Given this list of marker genes Esrp1, Rbpj, Notch1, Atoh1, Jag2, Dll1, here is a description of the gene set: Mouse Gene Set: GOBP_INNER_EAR_RECEPTOR_CELL_FATE_COMMITMENT The process in which a cell becomes committed to become an inner ear receptor cell. studied in species Mus musculus